Given this list of marker genes Tmem26, Eif4a1, Srsf9, Glrx, Ccl7, Socs1, Ccl9, Irf7, Ccl12, Fcgr2b, Hmox1, Ly86, Rap1a, Eif2s2, Serpina3g, Eef1e1, Cd209e, Ddx21, Srm, Ncl, Eif5a, Pdcd1lg2, Zfp593, Nabp1, Tomm5, Sdc4, Dkc1, Ap2m1, Chchd10, Ccl2, Ifrd2, Prps1, here is a description of the gene set: Cytokines mediate cell-cell communication in the immune system and represent important therapeutic targets. A myriad of studies have highlighted their central role in immune function, yet we lack a global view of the cellular responses of each immune cell type to each cytokine. To address this gap, the authors created the Immune Dictionary, a compendium of single-cell transcriptomic profiles of more than 17 immune cell types in response to each of 86 cytokines (>1,400 cytokine-cell type combinations) in mouse lymph nodes in vivo. A cytokine-centric view of the dictionary revealed that most cytokines induce highly cell-type-specific responses. For example, the inflammatory cytokine interleukin-1β induces distinct gene programmes in almost every cell type. A cell-type-centric view of the dictionary identified more than 66 cytokine-driven cellular polarization states across immune cell types, including previously uncharacterized states such as an interleukin-18-induced polyfunctional natural killer cell state. studied in species Mus musculus Mouse Gene Set: CUI_MACROPHAGE_IL4_RESPONSE_UP from publication Cui A, Huang T, Li S, Ma A, Pérez JL, Sander C, Keskin DB, Wu CJ, Fraenkel E, Hacohen N (PMID 38057668) Genes positively differentially expressed in cell type: Macrophage upon treatment with cytokine: IL-4 in mouse lymph nodes in vivo.